The following is a description of a gene set: studied in species Homo sapiens from publication Yevshin I, Sharipov R, Kolmykov S, Kondrakhin Y, Kolpakov F (PMID 30445619) Genes containing one or more binding sites for (ZFP37) in their promoter regions (TSS -1000,+100 bp) as identified by GTRD version 20.06 ChIP-seq harmonization. Human Gene Set: ZFP37_TARGET_GENES, and this is the list of marker genes: TRBV7-4, SUMO2P16, WNT8A, E2F3-IT1, VDAC1, CNTNAP2, LINC00431, SERP1